The following is a description of a gene set: Human Gene Set: HP_BIFID_UVULA Uvula separated into two parts most easily seen at the tip. studied in species Homo sapiens Bifid uvula, and this is the list of marker genes: TGFB3, IPO8, PIGW, EYA1, IFT140, KDM6A, PIGV, TP63, TXNL4A, TTN, RNU4-2, ZIC2, TBX22, PGAP3, IGBP1 (NCBI Gene Id 3476), SEC23A, GAS1, RPS23, ATP6V1B2, PIGL, PGAP1, ALG3, ZEB2, FGF10, DDX59, DLL1, CDC6, FGF8, POMT2 (NCBI Gene Id 29954), TWIST1, SKIC3, SLC2A10, SEPTIN9, INTS11, RPL5, CDON, COL11A1, FOXH1, DLK1, HAAO, GMNN, TGFBR1, MEG3, KCNK9, KIF7, MAP3K7 (mitogen-activated protein kinase kinase kinase 7), RFX7, SMCHD1, GJA8, METTL23, B3GALNT2, CHD4, HYLS1, COL11A2, SHMT2, GLI3 (GLI family zinc finger 3), HYAL1, ALG9, BIN1, PGM1, DDX3X, KIF14, COL4A1, RNU4ATAC, SMPD4, ORC4, SIX3, PTCH1, GRHL3, KMT2C, PIGY, KAT6B, USP9X, SLC39A13, KCNH1, CRIPTO, STIL, STAG2, GNAI3, FGFR1, RTL1, GJA5, AMER1, FILIP1, POMGNT2, PLCH1, ORC6, SIX1, HNRNPK, TBX1 (NCBI Gene Id 7413), UBB, POMK, FLNA, LARGE1, SPEG, B4GAT1, AMMECR1, B9D2, RPS28, BGN, CRPPA, IRF6, POMGNT1, ARMC9, TGDS, RXYLT1, GLI2, TCTN3, TGFBR2, TGIF1 (NCBI Gene Id 91941), DHCR7, ORC1, FTO, DHCR24, SMAD2, NODAL, TBCE, POMT1, SUPT16H, RYR1, BMP4, FBXO11, CDH11, FGFR3, PTDSS1, TGFB2, BCOR, SETD5, STAC3, SMARCD1, PGAP2, CDT1, KCTD1, SON, SMC1A, POLA1, DLG3, PLCB4, MYL11, FGFR2, KMT2D, PIEZO2, DAG1 (NCBI Gene Id 1605), ASPH, COL2A1, PPP1CB, SHH, RECQL4, CDC45, SIAH1, KDM6B, B4GALT7, FOXI3, XYLT1, POGZ, CUL3, SMAD3, FKTN, SNRPN, SELENOI, EIF4A3 (NCBI Gene Id 9775), SATB2 (SATB homeobox 2), SMAD4, DISP1, PIGO, FKRP, EDN1, SMS, KCNN3